Given this list of marker genes IFIT2, MFAP2 (NCBI Gene Id 4237), TOP2A, MAP2K3, NFKB2, SGK1, H1-0, EFNA1, TNFRSF12A, CCN1, SH3BP5, KLRC2, CD83, KRT19, FHL2, COL7A1, TXNRD1, SRSF5, NR4A1, H2BC12, RAB1A, NFKBIA, TRAF4, EGR3, IL6, JUNB, MCL1, ELL2, SDCBP, FUBP1, IER3, EPHA2, BCAR3, CYTH1, NFE2L2, EWSR1, FUBP3, SNAI2, CCND1, SRSF1, PLK2, LIMA1, here is a description of the gene set: The infection of human cells by adenoviruses leads to a gradual reduction in the activity of host cell functions while viral gene expression progresses in a regulated way. We used the DNA microarray technique to determine the transcriptional activity profiles of cellular genes upon infection with adenovirus type 12 (Ad12). The microarray data were validated by quantitative real-time PCR for genes which showed significant alterations after Ad12 infection. At 12 h postinfection, there is a striking up-regulation between 10- and 30-fold in the expression of the G1P2, IFIT1, and IFIT2 cellular immune response genes compared to mock-infected cells. At later stages of infection, when the majority of regulated cellular genes has been turned down, a limited number of cellular genes exhibit increased activities by factors of 3 or less. These genes belong to the signal transduction or transcriptional regulator classes or are active in protein degradation, like ANPEP, an aminopeptidase. The SCD and CYP2S1 genes function in lipid metabolism. The eucaryotic translation initiation factor 4 is up-regulated, and one of the major histocompatibility complex genes is diminished in activity. For two of the genes, one up-regulated (CTSF gene) and one down-regulated (CYR61 gene), alterations in gene activity were confirmed at the protein level by Western blotting experiments. Increased genetic activity of cellular genes late in adenovirus infection has not been reported previously and demonstrates that Ad12 has a sustained control of host cell gene expression well into the late phase of infection. Genes down-regulated in HeLa cells (cervical carcinoma) 24 h after infection with adenovirus Ad12. from publication Dorn A, Zhao H, Granberg F, Hösel M, Webb D, Svensson C, Pettersson U, Doerfler W (PMID 15681441) Human Gene Set: DORN_ADENOVIRUS_INFECTION_24HR_DN studied in species Homo sapiens